Given this list of marker genes HHAT, PSMD1, PSMC4, OS9, UBC, PSMB7, VCP, PSMB1, PSMC6, ADRM1, PSMD11, PSMD14, PSMA7, ERLEC1, PSMA1, PSMD3, SEL1L, PSMD13, PSMC5, PSMB4, RPS27A, PSMD7, SEM1, PSMC1, PSMA6, PSMA3, PSMA4, UBB, DHH, PSMC2, PSMB6, PSMB3, PSMB2, DERL2, PSMB5, PSMA2, SHH, PSMA5, PSMC3, PSMD2, PSMD8, SYVN1, PSMD6, PSMD12, UBA52, IHH, here is a description of the gene set: Hh mutants abrogate ligand secretion Human Gene Set: REACTOME_HH_MUTANTS_ABROGATE_LIGAND_SECRETION studied in species Homo sapiens